The following is a description of a gene set: Pathway Definition from KEGG: SLX == MUS81+EME1 == GEN1 Human Gene Set: KEGG_MEDICUS_REFERENCE_DOUBLE_HOLLIDAY_JUNCTION_RESOLUTION Double Holliday junction resolution. Pathway ID: N01448. Pathway type: Reference. Pathway class: nt06506 Double-strand break repair. studied in species Homo sapiens, and this is the list of marker genes: SLX1A, SLX1B, GEN1, EME1, SLX4, MUS81